The following is a description of a gene set: The cell cycle process in which replicated homologous chromosomes are organized and then physically separated and apportioned to two sets during the mitotic cell cycle. Each replicated chromosome, composed of two sister chromatids, aligns at the cell equator, paired with its homologous partner. One homolog of each morphologic type goes into each of the resulting chromosome sets. species: Mus musculus Mouse Gene Set: GOBP_MITOTIC_SISTER_CHROMATID_SEGREGATION, and this is the list of marker genes: Xrcc3, Cul3, Misp, Drg1, Rangrf, Rab11a, Psmg2, Kat2b, Ino80, Mad2l1, Tubg1 (tubulin, gamma 1), Cltc, Chmp4c, Stag2 (STAG2 cohesin complex component), Nsl1, Mad1l1, Smc4, Chmp3, Aurkb, Rad21, Tpr, Prap1, Uhrf1, Nudc, Ankrd53, Ripor2, Zwilch, Champ1, Eml3, Chmp7, Ccsap, Becn1, Phf13, Kif11, Smarca5, Fbxo5, Dusp1, Nusap1, Chmp6, Lsm14a, Seh1l, Rb1, Prickle1, Smc2, Tubg2, Numa1, Hspa1b, Pinx1, Mybl2 (myeloblastosis oncogene-like 2), Eml4, Clasp1, Rcc1, Cdt1, Spc24, Kif18b, Anapc7, Racgap1, Rrs1, Khdc3, Dync1li1, Spc25, Kif4, Ran, Poldip2, Sirt1, Nuf2, Ncapg2, Cenpi, Anapc15-ps, Smc3, Knstrn, Klhl22, Ccnb1-ps, Ncapd3 (non-SMC condensin II complex, subunit D3), Kif14, Cdc23, Map10, Vps4a, Kif2a, Apc, Kifc5b, Kntc1, Kif2c, Ccdc66, Zfp207, Abraxas2, Chmp4b, Tpx2, Atf6b, Pibf1, Kat5, Spdl1, Ofd1, Anapc11, Ccdc61, Spice1, Kifc1, Chek2, Abraxas1, Chmp5, Ncapg, Rhoa, Cdk5rap2, Haspin, Arhgef10, Nek2, Kif22, Dctn2 (dynactin 2), Plk1, Cenpk, Usp44, Mad2l1bp, Espl1, Hspa1a, Ttk, Akap8l (A kinase anchor protein 8-like), Katnb1, Map9, Kif15, Snhg15, Golga2, Trip13, Cdc16, Ndc80 (NCBI Gene Id 67052), Wapl, Ncaph, Cenpc1, Anapc5 (NCBI Gene Id 67965), Cit, Chmp2b, Zw10, Cep192, Wrap73, Mzt1, Bub3, Clasp2, Pcid2, Ska2, Spag5, Kpnb1, Chmp1b, Incenp, Ncaph2, Aaas, Kif3b, Gen1, Chmp1a, Nsmce2, Ska3, Nipbl, Vps4b, Psrc1, Cep97, Mis12, Knl1, Ube2c, Chmp2a, Prpf4b, Ik, Bccip, Kif18a, Cdca5, Ska1, Dis3l2, Ccnb1, Hnrnpu (NCBI Gene Id 98724), Kif23, Atm, Ppp2r1a, Ncapd2, Stag1 (STAG1 cohesin complex component), Arhgap33os, Birc5, Mapre1, Lcmt1, Flna, Cenpe, Bub1b, Akap8, Baz1b, Smc1a, Anapc15, Cdc20, Nup62, Zwint, Bub1, Tex14, Chmp1b2, Cdca8, Cdk1, Prc1 (protein regulator of cytokinesis 1)